Given this list of marker genes PPP2R2C, SPOCK1, KRT17P1, MRC2 (NCBI Gene Id 9902), SH3GL3, COL5A1, ZNF474, VCAN, LRRC15, SPOCD1, MANCR, FBN1, TGFBI, CGB3, MMP2, SCG5, FAP, PLAUR, PDGFRL, OLFML3, FN1, LHB, MDFI, ADAM19, here is a description of the gene set: from publication Mebarki S, Désert R, Sulpice L, Sicard M, Desille M, Canal F, Dubois-Pot Schneider H, Bergeat D, Turlin B, Bellaud P, Lavergne E, Le Guével R, Corlu A, Perret C, Coulouarn C, Clément B, Musso O (PMID 27191501) Methods: Liver progenitor cells were incubated in a WNT-enriched microenvironment for 72hrs (200 ng/ml mouse recombinant purified Wnt3A from R&D Systems). Gene pathways dependent on downstream _-catenin were studied by _-catenin knockdown with specific siRNA. Gene pathways blocked by extracellular SFRP-like Wnt inhibitors were studied by co-incubating cells with recombinant purified FZD8_CRD (300 ng/ml, from R&D Systems). Independent culture experiments performed in triplicate include untreated cells or cells incubated with scrambled siRNA or with _-catenin-specific siRNA or with FZD8_CRD, alone or in combination with Wnt3A. Human Gene Set: MEBARKI_HCC_PROGENITOR_WNT_UP_CTNNB1_INDEPENDENT Transcriptome of human HepaRG hepatocellular carcinoma liver progenitors in responses to a WNT3A-enriched microenvironment and dissection of pathways dependent on _-catenin and/or blocked by the SFRP-like Wnt inhibitor FZD8_CRD. studied in species Homo sapiens